The following is a description of a gene set: CLEC7A (also known as Dectin-1) is a pattern-recognition receptor (PRR) expressed by myeloid cells (macrophages, dendritic cells and neutrophils) that detects pathogens by binding to beta-1,3-glucans in fungal cell walls and triggers direct innate immune responses to fungal and bacterial infections. CLEC7A belongs to thetype-II C-type lectin receptor (CLR) family that can mediate its own intracellular signaling. Upon binding particulate beta-1,3-glucans, CLEC7A mediates intracellular signalling through its cytoplasmic immunoreceptor tyrosine-based activation motif (ITAM)-like motif. CLEC7A signaling can induce the production of various cytokines and chemokines, including tumour-necrosis factor (TNF), CXC-chemokine ligand 2 (CXCL2, also known as MIP2), interleukin-1beta (IL-1b), IL-2, IL-10 and IL-12, it also triggers phagocytosis and stimulates the production of reactive oxygen species (ROS), thus contributing to microbial killing. These cellular responses mediated by CLEC7A rely on both Syk-dependent and Syk-independent signaling cascades. The pathways leading to the Syk-dependent activation of NF-kB can be categorised into both canonical and non-canonical routes. Activation of the canonical NF-kB pathway is essential for innate immunity, whereas activation of the non-canonical pathway is involved in lymphoid organ development and adaptive immunity. part of: C-type lectin receptors (CLRs) Reactome Pathway: CLEC7A (Dectin-1) signaling studied in species Homo sapiens, and this is the list of marker genes: ITPR1, PSMD6, AHCYL1, UBE2D1, ADRM1, NFATC3, PSMA5, PSMC4, PSMD11, PSMD14, RELA, NFKB2, PSMD12, IL1B, CCL22, CARD9, PYCARD, MAP3K14, PSMD2 (NCBI Gene Id 5708), PPP3R1, PSMB2, NFKB1, PSMB7, PSMA6, TAB3, UBA3, NFATC2, UBE2V1, FBXW11, RPS27A, MALT1, SEM1, CHUK, TAB2, RELB, PSMC1 (NCBI Gene Id 5700), PSMD1, PSMC5, PSMD7, UBB, PSMC2, SRC, SYK, PSMD8, PLCG2, ITPR3, MAP3K7, UBE2D2, PSMB6, PSMD3, CARD11, UBA52, PDPK1, CASP8, UBE2N (NCBI Gene Id 7334), PSMB1, PSMC3, PSMA7, PSMB5, CCL17, CALM1, SKP1, PPP3CB, PPP3CA, IKBKG, ITPR2, PSMD13, BCL10, IKBKB, PSMB4, NFATC1, PSMA3, PSMA1, NFKBIA, CUL1, BTRC, CLEC7A, TAB1, PSMA2, TRAF6, PSMB3, UBE2M, PSMC6, CDC34, PSMA4, PRKCD, UBC